The following is a description of a gene set: Human Gene Set: GOBP_ANTERIOR_POSTERIOR_PATTERN_SPECIFICATION studied in species Homo sapiens The regionalization process in which specific areas of cell differentiation are determined along the anterior-posterior axis. The anterior-posterior axis is defined by a line that runs from the head or mouth of an organism to the tail or opposite end of the organism., and this is the list of marker genes: SRF, WNT2, COBL, HOXA7, RBPJ, BTG2, EN1 (engrailed homeobox 1), TBX6, HHEX, GPC3, CFC1, FOXH1, AXIN2, BMPR2 (NCBI Gene Id 659), HOXC8, TDRKH, POFUT1, NOG (NCBI Gene Id 9241), HOXD13, HES5, MLLT3, DLL3, RING1, CDON, HOXA9, PRKDC, SFRP1, BMI1, SIX3, PGAP1, HOXD8, CELSR2, HEYL, WNT5A, HIPK2, SKI, MSX1, HES3 (hes family bHLH transcription factor 3), MYF5, NR2F2, GLI3, ALDH1A2, OFD1, HOXD9, HNF1B, MESP2, TBX1, YY1, HOXC5, TSHZ1, LFNG, FEZF2, OSR1, NODAL, FEZF1, FOXF1, TCF15, CDX2, TAF10, HOXA5, ZIC3, GDF11, POGLUT1, GRSF1, EP300, LHX1, LEF1, CFC1B (cryptic, EGF-CFC family member 1B), HOXD4, PBX1, XRCC2, SFRP2, CYP26C1, CRKL, ETS2, SOX17, VANGL2, KMT2A, HOXB9, HOXA3, OTX1, BPTF, SMO, CTNNB1, PLD6, HOXD3, DCANP1, BMP2, FZD5, HOXD10, HOXB7, WNT1, ALX1, DDIT3, FOXC1, HOXB2, RIPPLY1, CTNNBIP1, HOXA2, CRB2, TGFBR1, PCDH8, ZBTB16, TBX18, CER1, HOXA6, HOXC11, HOXB8, GBX2, TBX3, LEFTY1, FOXA2, LEFTY2, SMAD3, TP53, AURKA, HOXB6, TASOR, CDX1, MED12, HES1, TIFAB, MEOX2, HOXC6, FUZ, PLXNA2, ALX4, TDRD5, WLS, NLE1, KAT2A, NOTCH1, ZEB2, NKD1, HES7, BARX1, RNF2, PSEN1, BHLHE41, HELT, TMED2, PCSK6, RIPPLY2, HOXC13, BASP1, MSGN1, DMRT2, FOXC2, MESP1, HOXB4, SIX2, MYF6, TDRD7, LRP5, SHH, PAX6, SEMA3C, BMPR1A, FOXB1 (forkhead box B1), PRICKLE1, SMAD2, CRIPTO3, HOXC9, CRIPTO, NRARP, FRS2 (NCBI Gene Id 10818), HOXA11, DLL1, ABI1, HES2, HES6, WNT3 (NCBI Gene Id 7473), WNT2B, ARC, NKX3-1, GATA4, PCGF2, LDB1, PBX3, ATM, OTX2, HOXB5, NEUROG1, WNT3A, BHLHE40, BMP4, EMX2, GDF3, HOXB3, HOXA4, HOXB1, CDX4, KDM2B, TDRD1, PALB2, WNT8A, HIPK1, PCSK5, DKK1, TBXT, ATP6AP2, MEOX1, MSX2, MIB1, NEUROD1, SMAD4, FGF8, HEY1, NCKAP1, TCAP, HOXC4, RARG, ACVR2B, HOXA10, HES4, WT1, TULP3, SSBP3, HEY2, TDRD6, PPP2R3A, HOXC10 (homeobox C10), EPB41L5, ACVR2A